Given this list of marker genes Otulin, Mrps24, Lppos, Rae1, Bcl7c, Eef2, Pigt, here is a description of the gene set: Mouse Gene Set: CUI_B_CELL_SCF_RESPONSE_UP species: Mus musculus from publication Cui A, Huang T, Li S, Ma A, Pérez JL, Sander C, Keskin DB, Wu CJ, Fraenkel E, Hacohen N (PMID 38057668) Cytokines mediate cell-cell communication in the immune system and represent important therapeutic targets. A myriad of studies have highlighted their central role in immune function, yet we lack a global view of the cellular responses of each immune cell type to each cytokine. To address this gap, the authors created the Immune Dictionary, a compendium of single-cell transcriptomic profiles of more than 17 immune cell types in response to each of 86 cytokines (>1,400 cytokine-cell type combinations) in mouse lymph nodes in vivo. A cytokine-centric view of the dictionary revealed that most cytokines induce highly cell-type-specific responses. For example, the inflammatory cytokine interleukin-1β induces distinct gene programmes in almost every cell type. A cell-type-centric view of the dictionary identified more than 66 cytokine-driven cellular polarization states across immune cell types, including previously uncharacterized states such as an interleukin-18-induced polyfunctional natural killer cell state. Genes positively differentially expressed in cell type: B cell upon treatment with cytokine: SCF in mouse lymph nodes in vivo.